The following is a description of a gene set: studied in species Mus musculus Reactome Pathway: Sensing of DNA Double Strand Breaks part of: DNA Double Strand Break Response electronically inferred by orthology from the curated human pathway This event has been computationally inferred from an event that has been demonstrated in another species.<p>The inference is based on the homology mapping from PANTHER. Briefly, reactions for which all involved PhysicalEntities (in input, output and catalyst) have a mapped orthologue/paralogue (for complexes at least 75% of components must have a mapping) are inferred to the other species., and this is the list of marker genes: Kat5, Mre11a, Nbn